Given this list of marker genes FAM219A, DESI1, CD200R1, NSD2, HTR2C, RAB8A, RUNDC3B, PPP3CB, ANKS1A, CDC14A, HACD3, EPDR1, LILRA1, MAP3K9, UBQLN4, SLC4A8, CA5B, ZDHHC16, CELF2, TNRC6B, FRAT2, AREL1 (apoptosis resistant E3 ubiquitin protein ligase 1), SRL (NCBI Gene Id 6345), ZNF280C, ANKRD34A, WDR47, ADCY6, ATXN10, CRY2, CDK5R2, ENSA, NLRC3, PRKCB, PGS1, CARMIL1, SELENOO, SPEG, SCG2, MYO1D, WASL, STX18 (NCBI Gene Id 53407), INCENP, ST20-MTHFS, PWWP3B, ZSCAN18, DACH1, VCF1, PKD1, APOA4, BACH2, TMCC2, CDK17, ADD3, ZNF704, CHCHD7, IRF2BP2, SCML1, MTPN, RAPGEF1, GANC, MAL2, ASPH, MAOA, SELENOI, PLEKHA1, XYLT1, PPDPFL, TRAM2, TXNDC5, EPPK1, BCL9L, LIMK2, CALB1, PHOX2B, LAMA4, PKD1L1, CUX2, CKMT2, ARL6IP1, TMCC1, ANGEL1, GAD1, SNCB, CHAC1, TNIK, MARF1, HHIP, MECP2, SH3RF1, BCKDHB, GLYR1, RNMT, GNB1, HLF, AFDN, DPY19L3, MEF2C, NEGR1, RPA1 (replication protein A1), PROSER3, TRABD, OLIG3, BCL11A, FARP1, DSCAM, LPP, CPEB2, EFR3A, MFAP5, GPSM3, GPR52, INPP5F, SLC24A2, DNAJC16, CCDC127, RAB14, NGB, MTHFS, KIAA1549, SYP, CHST1, TRIB1, NXPH1, KIF1C, REV3L, GP6, MAGEE1, here is a description of the gene set: studied in species Homo sapiens Genes predicted to be targets of miRBase v22 microRNA hsa-miR-1324 in miRDB v6.0 with MirTarget v4 prediction scores > 80 (high confidence targets). Human Gene Set: MIR1324 from publication Chen Y, Wang X (PMID 31504780)